Given this list of marker genes IFT56, IFT74, CLUAP1, WDR35, IFT88, IFT70A, IFT22, IFT140, IFT70B, IFT80, TRAF3IP1, IFT81, TRIM59, TTC21B (NCBI Gene Id 79809), TTC21A, UBXN10, IFT43, WDR19, IFT27, IFT52, IFT20, IFT46, IFT25, IFT57, IFT172, IFT122, here is a description of the gene set: A nonmembrane-bound oligomeric protein complex that participates in bidirectional transport of molecules (cargo) along axonemal microtubules. Human Gene Set: GOCC_INTRACILIARY_TRANSPORT_PARTICLE species: Homo sapiens